Given this list of marker genes SPRED2 (NCBI Gene Id 200734), FGF3, FGF22, FGF8, FGF2, FGF23, FGF17, SPRED1, FGFRL1, FGF18, FGF4, FGF5, FGF10, here is a description of the gene set: studied in species Homo sapiens FGFRL1 modulation of FGFR1 signaling Human Gene Set: REACTOME_FGFRL1_MODULATION_OF_FGFR1_SIGNALING